Given this list of marker genes PLIN5, STUB1, MIR34A, MIR27B, ASXL1, HUWE1, PAQR3, TWIST1, here is a description of the gene set: Any process that stops, prevents, or reduces the frequency, rate or extent of the peroxisome proliferator activated receptor signaling pathway. Human Gene Set: GOBP_NEGATIVE_REGULATION_OF_PEROXISOME_PROLIFERATOR_ACTIVATED_RECEPTOR_SIGNALING_PATHWAY studied in species Homo sapiens